Given this list of marker genes Hgf, Tns4, here is a description of the gene set: species: Mus musculus Reactome Pathway: MET interacts with TNS proteins part of: MET promotes cell motility electronically inferred by orthology from the curated human pathway This event has been computationally inferred from an event that has been demonstrated in another species.<p>The inference is based on the homology mapping from PANTHER. Briefly, reactions for which all involved PhysicalEntities (in input, output and catalyst) have a mapped orthologue/paralogue (for complexes at least 75% of components must have a mapping) are inferred to the other species.